The following is a description of a gene set: The process whose specific outcome is the progression of the thyroid gland over time, from its formation to the mature structure. The thyroid gland is an endoderm-derived gland that produces thyroid hormone. Human Gene Set: GOBP_THYROID_GLAND_DEVELOPMENT studied in species Homo sapiens, and this is the list of marker genes: RAF1, NKX2-5, PAX8, SHH, MAP2K2, HOXD3, SIX3, NKX2-1, SMAD3, HIPK2, MAP2K1, EDNRA, HOXB3, FOXE1, CGA, MAPK1, TG, MAPK3, SRF, FGF10, RAP1GAP, FGF8, EDN1, SIX1, BRAF, TUBB1, THRA, HOXA5, HESX1, HOXA3, TBX1